The following is a description of a gene set: a6b1 and a6b4 Integrin signaling from publication Schaefer CF, Anthony K, Krupa S, Buchoff J, Day M, Hannay T, Buetow KH (PMID 18832364) species: Homo sapiens Human Gene Set: PID_A6B1_A6B4_INTEGRIN_PATHWAY, and this is the list of marker genes: LAMB2, LAMC3, ERBB3, HRAS, SFN, YWHAQ, LAMA3, ERBB2, RPS6KB1, YWHAZ, RXRA, RXRG (NCBI Gene Id 6258), MET, MST1, YWHAG, RAC1, GRB2, LAMA5, YWHAE, EGF, MST1R (macrophage stimulating 1 receptor), ITGB4, PIK3R1, AKT1, LAMB1, ITGA6, YWHAH, CASP7, LAMA2, COL17A1, LAMB3, EGFR (NCBI Gene Id 1956, epidermal growth factor receptor), LAMA4, SHC1, LAMC2, ITGB1, LAMA1, LAMC1 (laminin subunit gamma 1), RXRB, PRKCA, PMP22, PIK3CA, YWHAB, IL1A, CDH1, CD9